Given this list of marker genes SHOC2, GRIN2A, PIK3R3, SHC4, PLA2G4E, RAC2, RAF1, TEK, REL (NCBI Gene Id 5966), MAPK10, EPHA2, RAC3, GNG11, ELK1 (NCBI Gene Id 2002), MET, PLCG2, EGFR, PLA1A, RASAL1, NTRK1, RAC1, BCL2L1 (BCL2 like 1), PAK1, FGFR2, IGF1R, MAP2K2, HRAS, HTR7, GRB2, AFDN, PLA2G2D, RALGDS, PRKACG, CALML6, PLA2G1B, PRKCB, PRKCA, PLD1, PTPN11, KSR1, PLA2G4D, KIT, CALM1, RALA, RASA3, CSF1R, PAK4, GNB1, FLT1, PAK5, CALML3, RAB5C, TIAM1, NGFR, RASA1, PIK3CA, RASGRP2, RASSF5, TTBK1, PIK3CB, BRAP, GNG4 (NCBI Gene Id 2786), PLA2G2A, ZAP70, GNGT2, PLD2, RAB5A, RAB5B, RAP1B, GNG7, KDR, GAB1, JMJD7-PLA2G4B, ARF6, RALBP1, BAD, GNB3, FGFR4, CALM3, GNG3, INSR, MAP2K1, PIK3CD, CHUK, RRAS2, AKT2, GNG10, IKBKG, MAPK1, PLA2G12B, RASGRP4, PLA2G2F, FGFR1, PLCE1, NF1, RGL2 (ral guanine nucleotide dissociation stimulator like 2, NCBI Gene Id 9264), PRKACA, PDGFRB, RASGRF1, MRAS, PDGFRA, PLA2G2C, SHC1, NFKB1, PLCG1, LAT, ETS1, RALB, AKT1, KSR2, PLA2G3, GAB2, ABL2, KRAS, CALML5, RAP1A, RGL1, FGFR3, RELA, PLA2G2E, RASA2, GNG5, PAK2, SOS1, GNG2, CALML4, MAPK8, PLA2G4C, PLAAT3, FASLG, GNG8, PLA2G4A, GRIN1, PAK6, RASAL2, RASSF1, FOXO4, PLA2G5, PLA2G4B, PIK3R1, RAPGEF5, PLA2G6, RASGRP3, GNB4, AKT3, EXOC2, RASAL3, ETS2, CALM2, RASA4, PRKCG (NCBI Gene Id 57013, protein kinase C gamma), PAK3, PLA2G10, PRKACB, SOS2, RASGRP1 (NCBI Gene Id 10125), MAPK3, CDC42, GNGT1, SHC3, RRAS, FLT3, NTRK2, BUB1B-PAK6, GNG12, MAPK9, PLA2G4F, FLT4, RASA4B, RHOA, PIK3R2, STK4, IKBKB, RASGRF2, GNB2, GNB5, PLA2G12A, SHC2, GNG13, RIN1, NRAS, ABL1, GRIN2B, SYNGAP1, here is a description of the gene set: Ras signaling Human Gene Set: WP_RAS_SIGNALING species: Homo sapiens